Given this list of marker genes HTR3B, CHRNA9, HTR3E, HTR3D, CHRNA10, HTR7 (5-hydroxytryptamine receptor 7), HTR3A, HTR6, HTR3C, GNAS, HTR2A, HTR1A, ADCY6, HTR2B, HTR2C, HTR4, here is a description of the gene set: The series of molecular signals generated as a consequence of a serotonin receptor binding to one of its physiological ligands. species: Homo sapiens Human Gene Set: GOBP_SEROTONIN_RECEPTOR_SIGNALING_PATHWAY